The following is a description of a gene set: from publication Chen Y, Wang X (PMID 31504780) studied in species Homo sapiens Genes predicted to be targets of miRBase v22 microRNA hsa-miR-188-5p in miRDB v6.0 with MirTarget v4 prediction scores > 80 (high confidence targets). Human Gene Set: MIR188_5P, and this is the list of marker genes: GPN1, CYBRD1, SUZ12, PCDH9, TNFSF4, OTUD1, MEF2C, ACVR2A, SRSF7, ZNF843, SLC12A2, FAM200A (NCBI Gene Id 221786), FOXN2, XRCC5, ZFP91, NIPBL (NIPBL cohesin loading factor), GET4, ZNF281, PHACTR2, EXOSC9, FNIP1, KAT7, SLC43A3 (NCBI Gene Id 55543), C15orf39, TMEM128, FUBP3, CEP97, DLG5, CAVIN2, B3GALT2, GPATCH2L, AFG1L (AFG1 like ATPase), PPP3R1, NBEA, ENDOV, FGFR2, BCL9, ZC4H2, FGD5, TOMM70, SFXN1, ATXN7, SPRED1, AKT1S1, CPNE8, WASHC4, JARID2, RSPO3, COG5, ZC3H12C, CHST9, ZNF611, AP1S3, CCNT2, LRRC1, GPC6, BPGM, TTC31, HNRNPR, CD2AP, TAPBP, ASXL3, ILRUN, SLC22A3, PHF3, STX18, SEMA4B, PTEN, MARS2, MAFB, FBXW7, STX6